The following is a description of a gene set: species: Homo sapiens Human Gene Set: GOBP_POSITIVE_REGULATION_OF_URINE_VOLUME Any process that increases the amount of urine excreted from the body over a unit of time., and this is the list of marker genes: NPR3, HYAL2, EDNRB, INPP5K, HAS2, NPPB, ADORA2A, DRD2, BTC, EDN1, NPR1, GNAI2 (NCBI Gene Id 2771)